The following is a description of a gene set: studied in species Mus musculus TNFR2 non-canonical NF-kB pathway Mouse Gene Set: REACTOME_TNFR2_NON_CANONICAL_NF_KB_PATHWAY, and this is the list of marker genes: Skp1, Lta, Tnfrsf25, Tnfrsf9, Tnfsf13, Tnfrsf12a, Tnf, Uba52rt, Psmd7, Birc3, Psmb3, Tnfsf14, Psma7, Psmd8, Psmc4, Cd40lg, Tnfrsf8, Tnfsf11, Edar, Psmb7, Tnfrsf4, Psmb2, Tnfrsf13c, Ubb, Psmd1, Psmd2 (proteasome (prosome, macropain) 26S subunit, non-ATPase, 2), Xiap, Chuk, Eda2r, Psmd13, Ltbr, Tnfsf9, Psma4, Ubc, Adrm1, Psma2, Edaradd, Psma3, Birc2, Tnfrsf13b, Psmb5, Tnfrsf1b, Psmd14, Traf3, Tnfsf18, Psmd11, Psmd12, Psmc6, Psmb1, Fbxw11, Traf2, Tnfrsf11b, Tnfrsf14, Psma5, Eda, Nfkb2, Psmc1, Tnfrsf18, Ube2m, Psmc5, Psma1, Psmb6, Tnfrsf11a, Tnfrsf17, Uba3, Tnfsf8 (NCBI Gene Id 21949), Tnfsf12, Tnfsf15, Cul1, Relb, Psmc2, Tnfsf13b, Ltb, Map3k14, Psmd3, Cd70, Psmd6, Cd27, Psma6, Rps27a, Uba52, Tnfrsf1a, Psmb4, Cd40, Psmc3, Tnfsf4